The following is a description of a gene set: studied in species Homo sapiens Human Gene Set: HP_EXAGGERATED_MEDIAN_TONGUE_FURROW Increased depth of the median tongue furrow. Exaggerated median tongue furrow, and this is the list of marker genes: GPC3, HNRNPK, SOX5, RPS6KA3, GPC4